Given this list of marker genes DPM1, DPM3, DPM2 (NCBI Gene Id 8818), here is a description of the gene set: Reactome Pathway: Synthesis of dolichyl-phosphate mannose Dolichyl-phosphate-mannose (DPM, DOLPman) is the donor of mannose groups in the synthesis of the dolichyl pyrophosphate-linked precursor oligosaccharide in asparagine-linked glycosylation, in the synthesis of the glycosyl phosphatidylinositol (GPI) anchor precursor, in protein O-mannosylation and in protein C-mannosylation. Its synthesis proceeds in two steps. First, cytosolic GDP-mannose reacts with dolichyl phosphate exposed on the cytosolic face of the endoplasmic reticulum membrane to form DPM with its mannose moiety oriented toward the cytosol. The DPM molecule then flips in the endoplasmic reticulum membrane, so that its mannose moiety is in the endoplasmic reticulum lumen, accessible to the enzymes that catalyze its transfer to growing glycolipids and glycoproteins. species: Homo sapiens part of: Post-translational modification: synthesis of GPI-anchored proteins; Synthesis of substrates in N-glycan biosythesis